The following is a description of a gene set: species: Homo sapiens Human Gene Set: GOBP_LEUKOCYTE_MEDIATED_CYTOTOXICITY The directed killing of a target cell by a leukocyte., and this is the list of marker genes: NOS2, ELANE, CD226, IGHE, SPI1, LILRB1, NKG7, RNF19B (ring finger protein 19B), EBAG9, KLRK1, LEP, HLA-F, PCYOX1L, TYROBP, PTPN6, VAMP2, TAP2 (NCBI Gene Id 92048), IL23A, RASGRP1, VAMP7, SERPINB4, NCR1, DAO (D-amino acid oxidase), TUBB, HLA-E, FCGR3A, PVR, CLEC12B, CD1B, EMP2, HLA-H, CD160, KLRC1, FCGR1A, GZMB, PRDX1, FCGR1BP, POMC, NCR3, CEACAM1, KLRC4, KIF5B, STX7, IL18 (interleukin 18), CXCL6, HLA-C (NCBI Gene Id 5674), CTSH, HLA-G, HCST, CD1D, ARRB2, MR1, STAT5A, TUBB4B, ULBP3, CRK, CD2 (NCBI Gene Id 914), KLRD1, NCF1, INPP5D (NCBI Gene Id 653796, inositol polyphosphate-5-phosphatase D), CEBPG, F2, PIK3CB, IL21, FCGR3B, DNASE1, AZU1, RIPK3, LAG3, PIK3R1, CD1E, NCKAP1L, IGHG1, CX3CR1 (C-X3-C motif chemokine receptor 1), KLRC3, CADM1, PIK3R6 (phosphoinositide-3-kinase regulatory subunit 6), SH2D1A, KLRC2, IL12B, CD1A, KLRF2, AP1G1, HLA-A, IL12A, CYRIB, FCGR2B, IL18RAP, RAB27A, IL7R, PTPRC, AGER, CORO1A (coronin 1A), STAT5B, MYD88, HLA-DRA, ARL8B, PPP3CB, STAP1, GFUS, DNASE1L3, SLAMF6, KLRC4-KLRK1, RAET1E, VAV1, P2RX7 (NCBI Gene Id 5027), NLRP6, KIR2DL4, SLAMF7 (SLAM family member 7), TIGIT (T cell immunoreceptor with Ig and ITIM domains), CLEC2A, B2M, GRB2, KLRB1, CRTAM, HLA-B, HLA-DRB1, CD1C, ARG1, NECTIN4, TREM1, TUSC2, HAVCR2, F2RL1, ITGAM, IL12RB1, KIR3DL1 (NCBI Gene Id 439925), XCL1 (NCBI Gene Id 92337), LYST, ULBP2, HPRT1, CTSG, SLC22A13, PLEKHM2, MICA, AZGP1, FADD, LGALS9, TGFB1, FCGR2A, ICAM1, CTSC, RAET1L, SERPINB9, SCNN1B, STXBP2, IL23R, FCGR2C, PRF1, RAET1G, NECTIN2, UNC13D, GZMM, LAMP1, ULBP1